The following is a description of a gene set: species: Mus musculus from publication Gross C, Dubois-Pot H, Wasylyk B (PMID 17704799) The ternary complex factor Net/Elk3 is downregulated in hypoxia and participates in the induction by hypoxia of several genes, including c-fos, vascular endothelial growth factor and egr-1. However, the global role of Net in hypoxia remains to be elucidated. We have identified, in a large-scale analysis of RNA expression using microarrays, more than genes that are regulated by Net in hypoxia. In order to gain insights into the role of Net in hypoxia, we have analysed in parallel the genes regulated by HIF-1alpha, the classical factor involved in the response to hypoxia. We identified about genes that are regulated by HIF-1alpha in hypoxia. Surprisingly, when we compare the genes induced by hypoxia that require either Net or HIF-1alpha, the majority are the same (75%), suggesting that the functions of both factors are closely linked. Interestingly, in hypoxia, Net regulates the expression of several genes known to control HIF-1alpha stability, including PHD2, PHD3 and Siah2, suggesting that Net regulates the stability of HIF-1alpha. We found that inhibition of Net by RNAi leads to decreased HIF-1alpha expression at the protein level in hypoxia. These results indicate that Net participates in the transcriptional response to hypoxia by regulation of HIF-1alpha protein stability. Genes specifically down-regulated in SEND cells (skin endothelium) at hypoxia after knockdown of ELK3 by RNAi. Human Gene Set: GROSS_HYPOXIA_VIA_ELK3_ONLY_DN, and this is the list of marker genes: TRIM8, MINPP1, EI24, CDKN2C, HOXD9, NAV1, MAFB, NREP, LAMA5, BRD3, ZBTB14, DOK4, AOX1, TP53INP1, CBX6, RACGAP1, ST3GAL4, CSF3, SIPA1, UBOX5, PXDN, KCP, KIF23, S100A4, CHEK2, PDRG1 (p53 and DNA damage regulated 1), MAPK14, IGFBP4, LMO2, STMN1, CDC25B, MKNK2, NCBP2, EIF2AK2, FASN, NDE1, PALD1, ABCG1, CENPA, CLDN15, MARCKS, PPARGC1B, NFIC, ARRB1